The following is a description of a gene set: part of: Post-translational protein modification Lipoate is an essential cofactor for five redox reactions: four in oxoacid dehydrogenases (active in energy and amino acid metabolism) and one in the glycine cleavage system (GCS). Lipoate synthesis and transfer to target proteins in mitochondria requires three steps. Octanoyl carried by ACP from mitochondrial fatty acid synthesis is first transferred to GCSH. In the second step, two sulfur atoms of an iron-sulfur cluster are inserted on the side chain, synthesizing the lipoyl group in a highly complicated reaction. Finally, lipoyl is transferred onto the lipoyl domains of the E2 subunits (DLST, DLAT, DBT) of the target enzyme complexes (OGDH, OADH, PDH, BCKDH). Defects in the enzymes catalyzing the three steps cause severe lactic acidosis and metabolic imbalances due to dehydrogenase deficiency. Mutations in the lipoyl carrier GCSH additionally cause hyperglycinemia, leading to epileptic encephalopathy, since GCSH moonlights in glycine catabolism. studied in species Homo sapiens Reactome Pathway: Protein lipoylation, and this is the list of marker genes: DLAT, LIPT2, LIAS, DBT, NDUFAB1, FDX1, DLST, LIPT1, GCSH, NFU1